The following is a description of a gene set: The meiotic cell cycle process where side by side pairing and physical juxtaposition of homologous chromosomes is created during meiotic prophase. Homologous chromosome pairing begins when the chromosome arms begin to pair from the clustered telomeres and ends when synaptonemal complex or linear element assembly is complete. Mouse Gene Set: GOBP_HOMOLOGOUS_CHROMOSOME_PAIRING_AT_MEIOSIS studied in species Mus musculus, and this is the list of marker genes: Trip13, Zcwpw1, Brip1, Rnf212b, Cpeb1, Sycp3, Tex11 (NCBI Gene Id 83558), Syde1, Ankrd31, 1700028K03Rik, Tex15, Hormad1, Psmc3ip, Sycp1 (NCBI Gene Id 20957), Mael, Ccne1 (NCBI Gene Id 12447), Mei4, Ube2b, 4930447C04Rik, Sirt7, Shoc1, Ago4, Bend2, Stag3, Tex12, Msh5, Kash5, Ccne2, Spo11, Mlh1, Rad21l, Meioc, Majin, Terb1, Syce2, Fancd2 (NCBI Gene Id 78247), Mcmdc2, Syce1, Tex19.1, Ehmt2, Syce3, Rec8, Mre11a, Sun1, Iho1, Ndc1, Rnf212, Mlh3, Terb2, Msh4, Meiob, Syce1l, Bag6, Prdm9, Morc2b, Ccnb1ip1, Dmc1, Spata22, Mnd1